Given this list of marker genes DVL2, YWHAE, LATS1, WWC1, WWTR1, LATS2, CASP3, STK4, AMOTL1, TJP1, AMOT, YAP1, NPHP4, AMOTL2, MOB1B, SAV1, YWHAB, MOB1A, TJP2, STK3, here is a description of the gene set: part of: Signal Transduction Human Hippo signaling is a network of reactions that regulates cell proliferation and apoptosis, centered on a three-step kinase cascade. The cascade was discovered by analysis of Drosophila mutations that lead to tissue overgrowth, and human homologues of its components have since been identified and characterized at a molecular level. Data from studies of mice carrying knockout mutant alleles of the genes as well as from studies of somatic mutations in these genes in human tumors are consistent with the conclusion that in mammals, as in flies, the Hippo cascade is required for normal regulation of cell proliferation and defects in the pathway are associated with cell overgrowth and tumorigenesis. This group of reactions is also notable for its abundance of protein:protein interactions mediated by WW domains and PPxY sequence motifs.<p>There are two human homologues of each of the three Drosophila kinases, whose functions are well conserved: expression of human proteins rescues fly mutants. The two members of each pair of human homologues have biochemically indistinguishable functions. Autophosphorylated STK3 (MST2) and STK4 (MST1) (homologues of Drosophila Hippo) catalyze the phosphorylation and activation of LATS1 and LATS2 (homologues of Drosophila Warts) and of the accessory proteins MOB1A and MOB1B (homologues of Drosophila Mats). LATS1 and LATS2 in turn catalyze the phosphorylation of the transcriptional co-activators YAP1 and WWTR1 (TAZ) (homologues of Drosophila Yorkie).<p>In their unphosphorylated states, YAP1 and WWTR1 freely enter the nucleus and function as transcriptional co-activators. In their phosphorylated states, however, YAP1 and WWTR1 are instead bound by 14-3-3 proteins, YWHAB and YWHAE respectively, and sequestered in the cytosol.<p>Several accessory proteins are required for the three-step kinase cascade to function. STK3 (MST2) and STK4 (MST1) each form a complex with SAV1 (homologue of Drosophila Salvador), and LATS1 and LATS2 form complexes with MOB1A and MOB1B (homologues of Drosophila Mats).<p>In Drosophila a complex of three proteins, Kibra, Expanded, and Merlin, can trigger the Hippo cascade. A human homologue of Kibra, WWC1, has been identified and indirect evidence suggests that it can regulate the human Hippo pathway. A molecular mechanism for this interaction has not yet been worked out and the molecular steps that trigger the Hippo kinase cascade in humans are unknown.<p>Four additional processes related to human Hippo signaling, although incompletely characterized, have been described in sufficient detail to allow their annotation. All are of physiological interest as they are likely to be parts of mechanisms by which Hippo signaling is modulated or functionally linked to other signaling processes. First, the caspase 3 protease cleaves STK3 (MST2) and STK4 (MST1), releasing inhibitory carboxyterminal domains in each case, leading to increased kinase activity and YAP1 / TAZ phosphorylation. Second, cytosolic AMOT (angiomotin) proteins can bind YAP1 and WWTR1 (TAZ) in their unphosphorylated states, a process that may provide a Hippo-independent mechanism to down-regulate the activities of these proteins. Third, WWTR1 (TAZ) and YAP1 bind ZO-1 and 2 proteins. Fourth, phosphorylated WWTR1 (TAZ) binds and sequesters DVL2, providing a molecular link between Hippo and Wnt signaling. species: Homo sapiens Reactome Pathway: Signaling by Hippo